The following is a description of a gene set: Abnormal nostril morphology species: Homo sapiens Human Gene Set: HP_ABNORMAL_NOSTRIL_MORPHOLOGY Abnormality of the nostril., and this is the list of marker genes: PURA, IFT122, LFNG, CERT1, PIGF, CPLANE1, TMEM218, STIL, CSPP1 (NCBI Gene Id 79848), MECP2, FLNB, COL11A2, GPC3, ATP6V1B2, NALCN, CDH11, MAP2K2, TRIP12, UFC1, EXOSC2, CHN1, LEMD3, ELN (NCBI Gene Id 2006), RIPPLY2, CD96, H3-3A, ZNHIT3, KIF15 (NCBI Gene Id 56992), SLC2A1, MEGF8, RBM10, ESAM, PEX11B, DLL1, SLC29A3, GJA5, TWIST2, RNU4-2, TCTN3, NOVA2, KCNA1, CNOT2, ROR2, DYNC1I2, FZD2, PTCH1, LMBRD2, COG8 (NCBI Gene Id 84342), AUTS2, DMXL2, INSR, BRF1, PRRX1, ABCC8, RNF2, BAP1, ATIC, ZNF462, ATP6V1E1, PEX14, ZNF423, CHMP1A, SMARCC2, PIGA, B3GALT6 (NCBI Gene Id 126792), GJA8, CACNA1B, RAC3, ADAMTS3, PAK3, ABCC9, PEX26, LRPPRC, RBM8A, KMT2D, RERE, SMARCD1, VPS35L, SLC25A46, MAP3K7, PTPRF, GNPAT, H4C5, EHMT1, CDON, SKIC3, ARL13B, MYMX, HMGA2, KDM1A, INPP5E, AP2M1, LIFR, SYNGAP1, UBR1, CEP55, PEX6, GRIN1, ASXL1, SMC1A (structural maintenance of chromosomes 1A), SNX14, ESCO2, TBX6, SPECC1L, MEG3, RNF125, BMP4, OTX2, SATB2, GCSH, PEX13, OCLN, FGF8, RMRP, B3GLCT, TMEM67, NFIX, SHOC2, GNAO1, SMARCB1, GNAI1, SETD1A, TMEM70, NFIB, PTEN, GDF11, INPPL1 (NCBI Gene Id 3636), ERF, SIK1, TBC1D24, CSNK2A1, DPYD, MESP2, PARS2 (prolyl-tRNA synthetase 2, mitochondrial), ADSL, SLC25A22, HDAC4, MYCN, ARID1B, KIF11, AXIN1, NGLY1, SIM1 (SIM bHLH transcription factor 1), GNS, MPLKIP, EBF3, NPHP1, SLC26A2, POLR1A, BUB1B, KLHL15, SETBP1, ACTG2, MAFB, DHCR24, FH, WDR19 (WD repeat domain 19), AKT1, FLII, CNOT3, COG1, KNSTRN, GRM7, TCTN2, GAS1, RALA, KCNE5, CDKL5, CDC42BPB, DDR2, UBE3B, KATNIP, CLCF1, MAB21L1, POLRMT, MEF2C, PIGT, ZIC2, SPTBN1, TBC1D20, SC5D, TAPT1, MID1, MARS2 (NCBI Gene Id 92935), MICU1, FGF3, DOCK7, SUMF1, XYLT1, PBX1, CCDC8, MED27, CEP104, PAX1, TRPV6, SALL4, RALGAPA1, WDR26, CEP41, DLL3, KATNB1 (katanin regulatory subunit B1), TMEM231, PIGQ, ZBTB24, SMARCA4, AIFM1, RAB3GAP1, GPC4, LTBP3, KRAS, VAC14, FBXO11, DVL3, RAD21, ATRX (ATRX chromatin remodeler), SLC4A10, GMNN, NSRP1, DEAF1, PAM16, IFT52, SLC6A9, IFT56, DNMT3B, PAX3, SNRPN, POLG2, BRD4 (NCBI Gene Id 90616), EXOSC1, OBSL1, WNT5A, CEP120, MN1, ZNF292, ARMC9, HIVEP2, DICER1 (NCBI Gene Id 4333), ACTB, TAF4, SCN1A, PIEZO2, FAM20C, ZC4H2, ADNP, RTL1, CRLF1, RPS6KA3, SMARCA2, BMP2, NFIA, IQSEC2, CRIPT, ACSL4, HIC1, WLS (Wnt ligand secretion mediator), RPGRIP1L, SMCHD1, SIN3A, PLOD3, NEXMIF, KCTD1, ZFX (zinc finger protein X-linked), LZTR1, FGD1, ATP6V1A, CRIPTO, ADGRG6, CANT1, CBY1, ARX, PLCB3, KDM5A, ATP6V0A2, TONSL, ASCC3, FBN1, POU4F1 (POU class 4 homeobox 1), KDM4B, BLTP1, TCTN1, CHD2, GJA1, COL11A1, FRMD4A, MKS1, FLI1, PPP1R15B, MSL3, NEUROD2, TUBGCP6, B9D2, YWHAE, NEDD4L, PPP1CB, NAA10 (NCBI Gene Id 8260), GAD1, IRX5, PEX19, PIBF1, SPART, MAPK8IP3, RAI1, SLC32A1, TMEM216, KCNJ8, PLCH1, ANKRD11, SUFU, CC2D2A, DOCK3, PDHA1, HDAC8, TRIM8, BICRA, TMEM94, IL6ST, PUF60, PAFAH1B1, CAMTA1, PEX2, COL2A1, FOXH1, EIF4A2, TRPM3, PIGY, MIPEP, PUS7, RAC1, GLI3, HK1, ATAD3A, TGDS, MED12L, CSGALNACT1, ALDH6A1, SIX3 (NCBI Gene Id 6496), NODAL, GPC6, ZMYM2 (NCBI Gene Id 7750), EYA1, PEX10, ANTXR1, TRIO, ARID2, TOGARAM1, SLC6A1, PRKD1, WWOX, GPAA1, RAB18, FGFR1, PLK4, PPP2R1A, MLXIPL, NXN, TRRAP, HOXB1, KCNJ6, FGFR2, PRKAR1A, TMEM53, WNT3, PMM2, VPS51, PIK3CD, EFTUD2, MYMK, MAPK1, TRAF7, BRCA1, PDE4D, SMG9, PHIP, MED25, PYCR2, ALG13, METTL23, EXTL3, CEP290, LONP1, SMARCE1, HPDL, TXNDC15, NIPBL, ECEL1, SCN2A, PPM1D, DVL1, AIMP2, SPEN, KIAA0753, PPP1R21, SH3PXD2B, IDUA, TOR1A, AHDC1, RECQL, RNU4ATAC, CBL, DISP1, PEX12, ZBTB20, ASXL3, RIC1, SPOP, KCNJ11, MADD, POU1F1, RHOBTB2, UNC80, WDR35, DPF2, DHCR7, AHI1, GLUL, SHH, NOTCH2, PNKP, ADAMTSL2, FIG4, DIS3L2, NR2F1, PEX3, SOX11, CASK, FTO, CUL7, POLR3A, HECW2, CTCF, NRAS, WDR4, DDX3X, KDM6A, TBCK, COL27A1, TRIP11, TAF6, SMS, TGIF1, TCF4, DNMT3A, PIGN, DDB1 (NCBI Gene Id 1642), SOX4, ZNF699, PLEC, GNPTAB (N-acetylglucosamine-1-phosphate transferase subunits alpha and beta), CREBBP, HYLS1, DHX37, B9D1, ALX4, NARS2, IFT43, SEC23A, PEX1, TUBGCP4, ARID1A, AFF4, KCNH1, KIF14, TMEM237, SETD5, TMEM138, IFT74, OFD1, HRAS, GBA1, SKI, PDE6D (phosphodiesterase 6D), KIAA0586, PEX16, SCN1B, DLK1, ASH1L, PAH, HES7, IER3IP1, SLC17A5, SMC3, TAF1, PRMT7, AMMECR1, AGA, BRAF, CPSF3, PIGP, TRMT10A, FBXO31, TMCO1, FAM149B1, FILIP1, FGFR3, PTH1R, PEX5 (NCBI Gene Id 5830), PAICS, MAP2K1, WAC, STAG2, NSD1 (nuclear receptor binding SET domain protein 1), BCL11A, ARL3, GLI2, RAB3GAP2